Given this list of marker genes Got2, Mrps36, Gnmt, Hoga1, Dlst, Amt, Grhpr, Dao, Dld, Hao1, here is a description of the gene set: part of: Metabolism of amino acids and derivatives species: Mus musculus electronically inferred by orthology from the curated human pathway This event has been computationally inferred from an event that has been demonstrated in another species.<p>The inference is based on the homology mapping from PANTHER. Briefly, reactions for which all involved PhysicalEntities (in input, output and catalyst) have a mapped orthologue/paralogue (for complexes at least 75% of components must have a mapping) are inferred to the other species. Reactome Pathway: Glyoxylate metabolism and glycine degradation